Given this list of marker genes NR0B1, NOG, GSX1, SOX2, CREB1, FGF10, ISL1, HMGA2, GHRH, SOX3 (SRY-box transcription factor 3), SRD5A1, FGF8, HES1, RBPJ, CDH1, GLI2, WNT4, POU3F2, DRD2, PROP1, BMPR1A, SLC6A3, MSX1, BMP4, GLI1, INHBB, ALDH1A2, NKX2-1, BMP2, GHRHR, FGF2, HESX1, GATA2, PITX1, LHX3, WNT5A, SALL1, TBX19, PAX6, POU1F1, SIX3, PITX2, OTP, here is a description of the gene set: species: Homo sapiens Human Gene Set: GOBP_PITUITARY_GLAND_DEVELOPMENT The progression of the pituitary gland over time from its initial formation until its mature state. The pituitary gland is an endocrine gland that secretes hormones that regulate many other glands.